Given this list of marker genes PPP1R13L, ERF, PDGFRB, SMARCAD1, KRT9, TACR3, DCLRE1C, ADAMTS2, CLCNKB, HS6ST1, RSPO1, LIPN, ZNF750, PHYH, MAP2K2, BRAF (B-Raf proto-oncogene, serine/threonine kinase), ADAMTS10, EPHB4, WRN, KRAS (KRAS proto-oncogene, GTPase, NCBI Gene Id 3845), DKC1 (dyskerin pseudouridine synthase 1), CIDEC, TTC7A, DSP, HSD11B1, PHGDH, KRT6C, GBA1, PKDCC, CWC27, LIG4, KCTD1 (potassium channel tetramerization domain containing 1), FBN1, ABHD5, TYR, FGFR3, RNF113A, FLG, SULT2B1, KANK2, CHD8, ADAMTSL2, CUL4B, MVK, SMAD4, LAMB3, DIP2B, USF3, LARP7, PSAT1, COL6A2, AFF4, SERPINB8, COL4A5, FGF17, NSMCE2, IL17RC, DDB2, BSCL2, GATA1, ERMARD, NECTIN4, PSMB8, ANOS1, AP1B1, HPGD, MCOLN1, LBR, ATP2C1, HLA-DRA, SEMA3A, CCDC141, SH3PXD2B, MSMO1, RAG1, PEPD, RHBDF2, ITGB6, WRAP53, SDR9C7, ALMS1, TRPS1, DPAGT1, MPLKIP, LRP1, NSDHL, EMD, KIF11, SOX10, IL2RB, VIPAS39, DSC2 (desmocollin 2), ALOX12B, PNPLA1, SUMF1, GLS, MAP2K1, PCSK1, AQP5, BLK, SLC45A2, AKT2, SLC12A3, SPINK5, KITLG, MDFIC, DST, GPR101, FIG4, KLLN, KDSR, GTF2E2, RECQL4, KRT5, COL17A1, LMNA (lamin A/C), TRIP4, AKT1, EXPH5, IL7R, RYR1, LAMC2, ABCA12, GNPTAB (N-acetylglucosamine-1-phosphate transferase subunits alpha and beta), LZTR1 (leucine zipper like post translational regulator 1), NEUROD1, NEK9, FGF8, ABCC8 (ATP binding cassette subfamily C member 8), TNFRSF1B, LTBP2, VPS33A, COL14A1, ITGB4, BUB1, TP63, IL17RD, ERCC4, COL6A1, NECTIN1, SERPINA12, DDR2, RIN2, SREBF1, PEX11B, KLF11, FHL1, AHSG, EBP, HRAS, CDSN, TRAF3IP2, TINF2, TRAPPC11, TGM5, FERMT1, APOA1, PIGL (NCBI Gene Id 9487), KLHL24, MBTPS2, CHD7, TERT, PERP, SMARCD2, NEU1, CRYAB, SDHB, INSR, SHOC2, ERCC3, DUSP6, RIT1, POMP, STAT4, CAVIN1, ANGPT2, PAH, APPL1, ORAI1, PEX3, KIT, GJB3, IGHG2, GJB6, ADA, SBDS, HDAC6, POFUT1, CHKB, DSG1, KRT2, IL1RN, DNAJC21, NHP2, NPM1, SYNE2, SMARCA2, ALDH3A2, DCC, NLRP1, NLRP3, KLK11, MARS1, ANAPC1, NAGA, GTF2H5, AAGAB, SERPINB7, KRT85, ELOVL4, SLC17A9, DOLK, MMP1, CLDN1, CYP4F22, PROKR2, TYMS, HNF1A, WDR11, IL2RG, XRCC4, LAMA3, IL36RN, PEX1, PHLDB1, INS, RIGI, AARS1 (alanyl-tRNA synthetase 1), ATP7A, STS, KRT10, CYP19A1, LSS, DPP9, SLC27A4, TRPM4, AIP, PROK2 (prokineticin 2), GNB2, PEX13, LEMD3, SDHC, WNT10A, SLCO2A1, NRAS, ANTXR2, PEX10, PEX16, KRT86, ERCC2, AAAS, FLG2, SOX18, TUFT1, XPA, HLA-B, IKBKG, PNPLA2, TUBB, COL6A3, PEX7, IL17F, KRT81, KRT13, PIEZO1, MAD1L1, POMC, EFL1 (NCBI Gene Id 79631), ATP2A2, MVD, ADAM10, MC4R, FLRT3, CFTR, CARD14, GJB4, LORICRIN, VEGFC, CSTA, ADRA2A, KRT17, SLURP1, UROS, LTBP3, RBP4, GMPPA, PSENEN, XPC, SPRY4, LTV1, ALOXE3, COPB1, NDNF, ELMO2, JARID2, ERCC6, NOD2, PPARG, PMVK, PLAAT3, CEL, PPOX, CAST, RNU4ATAC, ESR1, RTEL1, POLA1, MTX2, ENPP1, PDGFB, TERC, SLC29A3, NF1, CARS1, PEX26, RAG2, SPTLC1, ADAMTS17, ECM1, PEX19, FOS, ATL3, PAX4, JUP, KRT74, FDPS, IL17RA (interleukin 17 receptor A), PLEC, AGPAT2, SASH1, NOP10, COL1A1, TFE3, PI4KA, CTSC, CST6, KRT1, ST14, POGLUT1, COL12A1, POLR3A, CAV1, SPTLC2, KRT16, LIPE, PARN, FGFR1, GCK (NCBI Gene Id 2645), AP1S1, KDF1, GINS1, CARMIL2, ERCC5, COL7A1, LDHA, ATL1, SNAP29, PDX1, DSC3, SYNE1, NOTCH2, FLT4, CLEC7A, CTLA4, GJB2, PIK3CA, NIPAL4 (NIPA like domain containing 4), CDH3, KRT83, TARS1, PEX14, DSG4, PSMB4, TMEM43, ELOVL1, KRT14, SDHD, RMRP, UROD, SGPL1, RNU12, COG6, CD28, TAT, USB1, MPDU1, ZC4H2, PLIN1, ARSL, PLOD1, PEX2, STIM1, SRD5A3, GRHL2, PTEN, VPS33B (NCBI Gene Id 55513), PEX6, FITM2, GLB1, IDUA, CERS3, TGM1, PEX12, GJC2, ZMPSTE24, FEZF1, PIGA, CTC1, TRPV3, SUPT16H, SEC23B, KANSL1 (NCBI Gene Id 791085), DBR1 (debranching RNA lariats 1), KRT6B, FUCA1, HESX1, ARSB, KRT6A, GJA1, FKBP14, MAPRE2 (microtubule associated protein RP/EB family member 2), PEX5, MMP2, KCNJ11, GLA, PKP1, IGKC, ASPRV1, HNF4A, FGFR2, here is a description of the gene set: Human Gene Set: HP_THICKENED_SKIN Laminar thickening of skin. studied in species Homo sapiens Thickened skin